Given this list of marker genes FGF17, FGF1, FGF18, FGF2, FGFR3, FGF20, FGF23, FGF5, FGF8, FGF16, FGF4, FGF9, here is a description of the gene set: part of: FGFR3 mutant receptor activation Reactome Pathway: Signaling by activated point mutants of FGFR3 Activating point mutations in FGFR3 are found in the extracellular ligand-binding domain, the transmembrane region and the tyrosine kinase domain and are believed to result in ligand-independent activation of the receptor. These mutations, although initially characterized in the context of autosomal skeletal disorders, are now being identified in a range of cancers including bladder, cervical, breast, prostate, head and neck, and multiple myeloma. species: Homo sapiens